The following is a description of a gene set: Any process that modulates the frequency, rate or extent of a cytoplasmic pattern recognition receptor signaling pathway. studied in species Homo sapiens Human Gene Set: GOBP_REGULATION_OF_CYTOPLASMIC_PATTERN_RECOGNITION_RECEPTOR_SIGNALING_PATHWAY, and this is the list of marker genes: NLRX1, SMPDL3A, TKFC, TREML4, MEFV, ZCCHC3, RIOK3, PPT1, SLC15A3, SLC46A2, ANKRD17, PUM1, HMGB1, EIF2AK2, IFI16, CARD8, MIR708, TAB1, OASL, PTPRS, CSNK1A1, CAV1, RNF125, F2RL1, MARK4, ZDHHC9, RNF39, CD36, BTK, TSPAN6, DHX33, TREX1, IRGM, PRKDC, PARP1, PYDC2, LYPLAL1, PPP6C, SIRT2, C1QBP, DDX60, NOP53, GPATCH3, XIAP, USP17L2, ZC3HAV1, FLOT1, HCFC2, LAMP2, PYDC1, OGT, NEK7, FBXL2, BIRC3, ZNRF4, KCNK13, AKT1, ABHD8, HDAC6, PYDC5, AARS2, HSPA8, HSPA1B, PTPN22, ZDHHC12, ERBIN, WDFY1, SPSB3, TRIM31, TRIM3, GBP5, TAX1BP1, CPTP, FLOT2, SEC14L1, MAVS, GRAMD4, MAP3K7, ZDHHC18, TNFAIP3, TRIM15, TARBP2, ZDHHC5, GBP2 (guanylate binding protein 2), SLC15A2, UBQLN1, ABHD17A, PCBP2, PPP2CA, PUM2, BRCC3, TRIM11, STMP1 (NCBI Gene Id 649778), SRC, RSAD2, MAPK8, NLRC3, KCNK6, HSPA1A, ATAT1 (alpha tubulin acetyltransferase 1), USP50, BIRC2 (NCBI Gene Id 329), ZDHHC1, NAGK, NPLOC4, AURKB, TLR6, CGAS (cyclic GMP-AMP synthase), TIRAP, BANF1, FCRL3, LATS1, SLC15A4, PLCG2, UFD1, PELI1, LILRA4, TREM2, MYD88, RTN4, RAB7B, DHX58, DDX3X, SLC19A1, ZDHHC3, TLR4, MARCHF5, MIR4691, ITCH, TASL, USP15, TLR9, PRKD1, NLRP2B, LATS2, TRIM65, P2RX7